Given this list of marker genes TMEM120A, PRDM2, DSE, TXNIP, C1orf74 (NCBI Gene Id 148304), SP4, TEAD2, SLC40A1, DENND2D, APTX, GEN1, FMC1 (formation of mitochondrial complex V assembly factor 1 homolog), MXD3, SPACA9, LAIR1, IRAK1BP1, PLA1A, NPRL2, ZNF827, WSB2, FOXD2, ESCO2, KATNBL1, DARS2, GNB4, SEH1L, ZC2HC1A, CLYBL, RTN4RL1, PNKP, NAPRT (nicotinate phosphoribosyltransferase), MMP9, HYCC1, SGO2, PROM1, ITGA10, C1QL3, ATP6V0B, ADD1, TSSC4, CIAO3, VPS13B, FPR2, IFIT1, WWP2, AP4B1, RAB3D, LPL, ZDHHC7, MAJIN (membrane anchored junction protein), SCFD2 (sec1 family domain containing 2), JMJD7-PLA2G4B, KIF18B, APBB3, ARHGAP10, GXYLT1, ARMC6, UBAP2L, CCNB1IP1, GPR68 (NCBI Gene Id 8111), DPP8, ECHDC3, SYNJ1, SNAI3, RIPK1, SREBF1, MDC1, GPR160, SLC26A6, ANKH, SNTB2, PLEKHM1, FAM220A (NCBI Gene Id 84792), TSPOAP1, DMXL2, CHL1, SKA1, CCNK, SMURF2, FXYD5, BORCS6, VPS13D, CYTH4, REEP4, LUZP1, NAT9, MUTYH, SNAPC5, DZANK1, TENT5C, TOP3B, ERCC4, ERGIC3, SUSD1, XRN1, MXRA7, GRAMD1C, SDF4, RFXANK, RASGEF1A, RBX1, TESK1, STK39, RNF20, PRR5L, FAM219B, PHF1, GRB2, KIF1B, TMUB2, SLC46A3, PTCD2, TSPYL4, TAPBP, WDR44, GPSM2, ZNF324B, FBXO17, SNRNP27, TRABD, RNF214, GEM, PIK3CG, KLHDC4, TNFSF9, STK38L, SDR42E1, TRAF2, SCML4, ELMO2, PTTG1, RAD51B, DNAAF5, HROB, PDLIM7, PREX1, PIR (NCBI Gene Id 8544), HOMER1, ZNFX1, NCALD, KCTD9, VAMP2 (NCBI Gene Id 6844), H1-4, ZC3HAV1, MAX, FANCB, PHACTR4, ACSS2, SMYD4, CAMK2N1, CCDC82, ADGB, FAM210B (NCBI Gene Id 81895), LRMDA, FLCN, BTBD6, SUGT1, INPPL1, HEATR5B, RAD54L2, C22orf39, MEGF9, RAP2A, CDK14, SHTN1, TMEM175, JOSD2, COQ10B, QPRT, ADGRB2, LMNB1, ACBD4, SORL1, ARID5A, VAV1, FMNL1, SLC15A3, RHOC, STYK1, NFIL3, PIDD1, ARRDC4, C1orf122, GPR132, ITLN1, KIFC3, ZBTB48, POLH, CDR2, KDM7A, CX3CR1, FBXO30 (NCBI Gene Id 84085), MCU, TYK2, FBXL14 (F-box and leucine rich repeat protein 14), CAMKK1, ADAP1 (NCBI Gene Id 11033), DPF2, GDAP2, here is a description of the gene set: species: Homo sapiens Primary HBE cells were stimulated with IL-22 and IL-17, and gene expression was studied using an Affymetrix platform microarray, in order to investigate which genes may be upregulated or downregulated in response to these cytokines. Of particular interest was the host defense genes such as antimicrobial peptides, which have been shown to be upregulated by IL-22 and IL-17 in skin keratinocytes. from publication Aujla SJ, Chan YR, Zheng M, Fei M, Askew DJ, Pociask DA, Reinhart TA, McAllister F, Edeal J, Gaus K, Husain S, Kreindler JL, Dubin PJ, Pilewski JM, Myerburg MM, Mason CA, Iwakura Y, Kolls JK (PMID 18264110) Human Gene Set: GSE10240_IL17_VS_IL17_AND_IL22_STIM_PRIMARY_BRONCHIAL_EPITHELIAL_CELLS_UP Genes up-regulated in primary bronchial epithelial cells stimulated with: IL17A versus IL17A and IL22.